Given this list of marker genes PNKP, SOX10, STIM1, WDR81, PIK3R5, B4GAT1 (NCBI Gene Id 11041), DHH (NCBI Gene Id 791256), MYOT, ACD, TSPYL1, EXTL3, DKC1, PEX6, KCNC2, TBCK, TERT (telomerase reverse transcriptase), EGR2, SCN3A, AGTPBP1, MTPAP, KY, RMND1, GNAS, IYD, SCN8A, PMM2, HADHB, GTF2H5, CACNA1S, BAG3, PRKCG, GABRA3, DBH, HSPB1, MT-ND2, CLTC, SLC25A19, ALDH5A1, DNMT1, CPT1A, GLDC, CARS1 (cysteinyl-tRNA synthetase 1), LMOD3, DUOX2, SCN9A, PHKG1, TRMU, SETX, PGM3, PTRH2, TSEN15, DNAJC6, LITAF, TBC1D23, MPLKIP, SYT2, PYROXD1 (pyridine nucleotide-disulphide oxidoreductase domain 1), MED25, COX6A1, VWA1, PHKA1, ERCC3, AGRN, NARS2, CRPPA, AIFM1, COLQ (collagen like tail subunit of asymmetric acetylcholinesterase), SNIP1, TRAK1, ATP6V1B2, FHL1, TPO, PARS2, SMN1, ACO2 (NCBI Gene Id 50), SLC25A46, POMT1, CNKSR2, FBN1, ERCC6 (ERCC excision repair 6, chromatin remodeling factor), HMBS, PRDM12, BSND, HDAC4, FIG4, MAG, LDB3, ATXN2, GARS1, PRX, PEX5, IBA57 (NCBI Gene Id 200205), ACTA1, CACNA1A, PRDM13, SQSTM1, LMNA, VAPB, PTF1A, NDUFAF2, LRSAM1, TTR, GABRG2, HSPB8, CELF2, COA7, TRIM32, HADHA, VPS33A, MT-ND3, B4GALNT1, CACNA2D1, ATXN10, ABHD12, ELOVL4, MT-TL1, CHAT, GRIN2D, SCO2, ZFHX3, KIAA0586 (KIAA0586), SYNGAP1, MRE11, PIGB, TMEM240, TWNK, RAI1, SPTAN1, MT-TV, WNK1, NOTCH2NLC, TRMT5, TARS1, POLG2, MT-TE, NGLY1, SZT2, MPZ, HESX1, SLC35A1, LRP4, TRPV4, GNPTAB, COL13A1, DARS2, COASY, RETREG1, MYH14, SEPTIN9, LARGE1, XPA, DHTKD1, ATL3, AR, ADSS1, GAA, IQSEC2, CLCNKB, PLP1 (NCBI Gene Id 5354), GBF1, SLC38A3, KARS1, SUCLA2, MCM3AP, NEFH, VCP, NUS1, ATP9A, MYO9A, KIF1A, LGI3, HCN1, MORC2, FDX2, PNPT1, LHX3, DMD, PEX2, PIGN, GBE1, MYPN, GABRB2, SLC1A2, DCAF8, SLC25A4 (NCBI Gene Id 7872), NDUFA9 (NADH:ubiquinone oxidoreductase subunit A9), POMT2, PPP3CA, KLHL41, PUM1, FBLN5, EXOSC3, HNRNPDL, TBK1 (NCBI Gene Id 29110), FUS, UBAP2L, GABRA2, EXOSC8, TMCO1, NDUFS4, BEAN1, MME, REEP1, PEX7, ELP1, ST3GAL5, SMPD1, PACS2, EXOSC9, DPAGT1, IFRD1, COG7, ATP1A3, VPS13A, CDK19, FBXO28, ATN1, GAN, ATP7A, BICD2, ARHGEF2, FASTKD2, EXOSC1, DUOXA2, SPTLC2, GJB1, UBA5, TRIM8 (tripartite motif containing 8), DHDDS, POMGNT1, CCDC47, IGHMBP2, PIEZO2, DALRD3, LPIN1, DNM2 (NCBI Gene Id 338330), NARS1, IARS2, PPP1R21 (protein phosphatase 1 regulatory subunit 21), GABRA5, RYR1, RRM2B (ribonucleotide reductase regulatory TP53 inducible subunit M2B), ACOX1, ATP1A1, HSPG2, PMP22, SELENON, ACAT1, MT-ND1, FGF12, VRK1, FKRP, FLII, TSHB (NCBI Gene Id 7252), DES, CNTNAP1, SLC5A5, AARS1, KBTBD13, PEX1, MGME1, NECAP1, GDAP1, EEF1A2, RAB7A, MT-TW, MSTO1, KIF1B, MT-ND4, NAGLU, CNBP, PPOX, HSD17B4, AP3B2, DNM1, SMN2, ZSWIM6, LRRK1, AARS2, FBXO38, CNTNAP2, DYNC1H1, TARDBP, KCND3, TRAPPC11, SCN1A, NDUFA1, POU1F1, TG, DAG1, PARN, EMC1, VAMP1, GABBR2, SNAP25, MDH2, INF2, ATXN1, TK2, ATP1A2, GALC, KCNA2, DEAF1, POLR3B, DGUOK, ATP6AP2, NDRG1, ERCC2, PSAP, POMK, WARS1, RXYLT1, C19orf12 (chromosome 19 open reading frame 12), WWOX, TPM2, STAC3, TSHR, GRIA3, NEB, KLC2, LAMB2, ARSA, SNRPN, PMPCA, SLC5A7, DHX30, RTEL1, COL4A1, SLC13A5, GBA1, MFN2, GRIN2A, PNPLA6, STX16, RUBCN, TUBA8 (tubulin alpha 8), RNASEH1, MEGF10, QRICH1, MT-TK, MT-ND6, RNF170, PEX12, NTRK2, KCNJ18, TAOK1, FZR1, ACTL6B, SNX14, YWHAG, SYNE1, FKTN, ABCA1, SHANK3, FOXG1, CACNA1B, GNB4, HK1, KCNB1, SLC25A1, TPM3, FMR1, POLG, SCYL1, HMGCR, PHYH, CLCNKA, CYFIP2, TBC1D24, FLI1, SLC18A3, PDHB, RNF113A, NEFL, APTX, FLRT1, DYSF, COX8A, POMGNT2, GEMIN4, LYST, MYH7, SPTLC1, PODXL, MT-ATP6, PIGG, MPV17, B3GALNT2 (beta-1,3-N-acetylgalactosaminyltransferase 2), CHCHD10, SYNJ1, ANXA11, GTF2E2, LHX4 (NCBI Gene Id 89884), ATP6V1A, CFL2, SIL1, RFC1, PEX10, FLNC, TPI1, RAP1GDS1, PDK3, SBF2, MT-ND5, CRYAB, TINF2, DOCK3, HMGCL, PROP1, FGD4, NFASC, here is a description of the gene set: Hyporeflexia Human Gene Set: HP_HYPOREFLEXIA species: Homo sapiens Reduction of neurologic reflexes such as the knee-jerk reaction.